Given this list of marker genes Dhcr24, Elk4, Sat1, Stk39, Steap4, Ube2i, Azgp1, Tpd52, Idi1, Mak, Gucy1a1, Adrm1, Herc3, Xrcc5, Fads1, Tmprss2 (transmembrane protease, serine 2), Ptpn21 (protein tyrosine phosphatase, non-receptor type 21), Rps6ka3, H1f0, Zmiz1, Abhd2, Abcc4, Sms-ps (spermine synthase, pseudogene), Gpd1l, Hmgcr, Maf, Hsd17b14, Tnfaip8, Srp19, Plpp1, Ncoa4, Ank, Krt8, Adamts1, Gsr, Ube2j1, Slc26a2, Cdc14b, Uap1, Mertk, Camkk2, Bmpr1b, Fkbp5, Ccnd1, Gnai3, Ndrg1, Srf, Appbp2, Rab4a, Xrcc6, Itgav, Pias1, Acsl3, Vapa, Aldh1a3, Selenop, Pmepa1, Ptk2b, Pgm3, Sord, Ccnd3, Inpp4b, Insig1, Tsc22d1, Map7, Arxes2, Dbi, Lman1, Zbtb10, Pa2g4, Dnajb9, Pdlim5, B4galt1, Spdef, Hpgd, Ngly1, Hmgcs1, Akt1, Iqgap2, Sgk1, Nkx3-1, Lifr, Arid5b, Sec24d, Cenpn, B2m, Slc38a2, Elovl5, Actn1, Tmem50a, Cdk6, Akap12, Krt19, Homer2, Ell2 (NCBI Gene Id 192657), Rrp12, here is a description of the gene set: studied in species Mus musculus Mouse Gene Set: HALLMARK_ANDROGEN_RESPONSE from publication Howe DG, Blake JA, Bradford YM, Bult CJ, Calvi BR, Engel SR, Kadin JA, Kaufman TC, Kishore R, Laulederkind SJF, Lewis SE, Moxon SAT, Richardson JE, Smith C (PMID 30224793) Mouse genes annotated to HALLMARK_ANDROGEN_RESPONSE based on orthology mappings provided by the Alliance Genome Consortium